Given this list of marker genes Sprr1a, Ctsh, Hoxc8, Col6a3, Col6a2, Acadm, Mvk, Thbd (thrombomodulin), Il1rn, Tpsab1, Hnf1b, Hspb8, Cd93, Gas1, Enpp2, Pitx2, Ccl9, Gsta4, Cap1, Mgp, Col6a1, Prl2c3, Rspo2, Foxc2, Mgll, Gata6, Twist2, Dffb, Arhgdib, Cdkn1b, Limk1, Cd53, Thbs2, Tgfbi, Grem1, here is a description of the gene set: species: Mus musculus Genes down-regulated in fibroblasts from MLL knockout mice. The human mixed lineage leukemia (MLL) gene is involved in about 50 different chromosomal translocations, associated with the disease phenotype of acute leukemia. However, the normal function of MLL is less understood. Homozygous knockouts of murine Mll were embryonal lethal, while heterozygous disruption led to aberrant hox gene expression associated with skeletal malformations, growth retardation, and impaired hematopoiesis. To understand MLL functions on the molecular level, gene expression profiling experiments were performed with a pair of murine cell lines (MLL(+/+) and MLL(-/-)). Microarray hybridization experiments revealed 197 potential target genes that are differentially expressed, providing new and important clues about MLL functions. Mouse Gene Set: SCHRAETS_MLL_TARGETS_DN from publication Schraets D, Lehmann T, Dingermann T, Marschalek R (PMID 12789274)